Given this list of marker genes ASH1L, METTL9, ZNF461, AKR1B1, PCDH8, NFYB, CD28, KBTBD2, COX14, RAP1B, RBSN, FAM131B, KCNA1, APLN, HS3ST3A1, PPP1R14C, OASL, HDAC2, KCNJ10, RNF135, GMCL1, SNX7, GPR156, TMEM104, ANKRD27, HIC2, TOGARAM1, FAM13A (family with sequence similarity 13 member A), ZNF131 (zinc finger protein 131), ACSBG1, DDX23, JADE2, ARL5A, TOR3A, DLX1 (NCBI Gene Id 1745), STX6, ELP1, PHTF2, FAIM2, TGFB3, ATP4B, PPTC7, SMIM17, CEP57, PAK6, ARRB1, ATP1B4, STAM, PSMB2, TBX3, NR2C2, RUNX1T1, here is a description of the gene set: Genes predicted to be targets of miRBase v22 microRNA hsa-miR-631 in miRDB v6.0 with MirTarget v4 prediction scores > 80 (high confidence targets). species: Homo sapiens Human Gene Set: MIR631 from publication Chen Y, Wang X (PMID 31504780)